The following is a description of a gene set: studied in species Mus musculus Mouse Gene Set: GOBP_NEGATIVE_REGULATION_OF_CHONDROCYTE_DIFFERENTIATION Any process that stops, prevents, or reduces the frequency, rate or extent of chondrocyte differentiation., and this is the list of marker genes: Adamts7, Bmp4, Rflnb, Snai2, Gdf5, Sox9, Ptpn11, Ctnnb1, Rflna, Rarg, Ltbp3, Chadl, Ihh, Nr5a2, Mkx, Pth, Nkx3-2, Efemp1 (NCBI Gene Id 216616), Tgfbr1, Ccn4, Gli3, Gli2, Rarb (retinoic acid receptor, beta), Wnt9a, Pthlh, Grem1, Adamts12